The following is a description of a gene set: Sulfide oxidation to sulfate Mouse Gene Set: REACTOME_SULFIDE_OXIDATION_TO_SULFATE species: Mus musculus, and this is the list of marker genes: Slc25a10, Sqor, Tstd1 (thiosulfate sulfurtransferase (rhodanese)-like domain containing 1), Suox, Ethe1